Given this list of marker genes JUP, KIT, ITGB5, IHH (NCBI Gene Id 50819), PKP3, CCN3, DSP, CYP1B1 (NCBI Gene Id 1545), SRF, CAMSAP3, VCL, THBS4, SERPINB8, KIFC3, BVES, CTNNA1, DSC3, PLEKHA7, here is a description of the gene set: studied in species Homo sapiens The attachment of an epithelial cell to another epithelial cell via adhesion molecules. Human Gene Set: GOBP_EPITHELIAL_CELL_CELL_ADHESION